Given this list of marker genes PITPNM3, CENPF, RPGRIP1, PEX6, FGFR3, MVK (mevalonate kinase), IDH3A, WT1, LYZ, BEST1, DLK1, METTL27, CYP27A1, MT-CO1, SEMA4A, ZNF513, DDB2, BBS5, UFD1, GLA, PRPH2, ATF6, EPAS1, HEXA, LRAT, WIPF1, USP45, PSMB8, ERCC6, RAX2, RTL1, CCDC28B, ABCC6, ERCC2, TGFBI, SPATA7, LYN, OFD1, CCM2, PRPF6, ARL2BP, TFRC, YME1L1, ERCC3, MASP1, ARVCF, TBL2, FKBP6, KIAA1549, MT-CYB, RAG2, NEK2, HK1, CNNM4 (NCBI Gene Id 619531), SPI1, RGR, NCF1, RTTN, NEK1, MPLKIP, MT-ND1, AIPL1, PIK3R1 (NCBI Gene Id 5295), CARS1, MERTK, MAK, PDE6A, GTF2IRD2, NOD2 (NCBI Gene Id 8135), HSD11B2, TNFRSF13B, MT-ND4, AHI1, DNMT3B, AP1G1, SDHD, IGSF3, NRL, LAMB2, CFAP418, GMPPA, TNFRSF13C, TOPORS, NUS1, IMPG2, CLCNKB (NCBI Gene Id 1188), RNF113A, FGF10, SLC6A6, SNRNP200, ASAH1, FZD4, CACNA2D4, CNGA1 (cyclic nucleotide gated channel subunit alpha 1), SHMT2, GNAT2, COL4A1, EFEMP1, LCA5, CDHR1, MAPT, IGFBP7, SDHC, FRG1, GJB6, MTTP, KLRC4, SAG, KLHL7, AARS1, MEFV, ESS2, RP2, STAT4, C4A (NCBI Gene Id 720), SAMD9, IGHM, RDH12, OPN1LW, PSMB4, PDCD10, JMJD1C, IARS2, ARL6, HIRA, STN1, NBN, FSCN2, HBB, LRBA, GPIHBP1, SMPD1, BTD, ESAM, AEBP1, SLC39A4, ANTXR1, AAAS, MT-ATP6, LIMK1, ZFX, CNGB3, DNMT3A, STX16, BUD23, FLVCR1, PDE6C, SETD2, TCF3, TBK1, POLH, GUCY2D, BTNL2, CR2, RPE65, BBS2, NDP, TP63, PLG, ARV1, EYS, TRIM44, HGSNAT, TBX1, RP9, HLA-DRB1, GUCA1B, SERPINC1, VPS37D, CTNNB1, ADA2, DKC1, TARS1, COMT, IMPDH1, RREB1, DNAJC30, BAZ1B, DHDDS, ABCA4, PRPF31, CCR1, PAX1, STX11 (syntaxin 11), NDUFS2, IMPG1, ADAM9, WDR19, IFNGR1, RBP3, CTSA, TMEM270, IL10, SASH1, CD19, ARL3, MT-ND5 (NCBI Gene Id 4540), IDH3B, FAM161A, DARS1, MEG3, NR2E3, ENG, RDH5, MYD88, SLC7A14, PCNA, ENPP1, DUX4L1, RET, ACVRL1, ATP2A2, XPA, IFT88, STX1A, FH, LCK, SMAD4, RHO, DRAM2, AIRE, MANBA, BTK (NCBI Gene Id 695), MT-ND2 (NCBI Gene Id 4536), SREBF1, SLC24A1, ERCC4, SCN9A (NCBI Gene Id 93955), APOE (NCBI Gene Id 99), VHL, GTF2E2, DGCR8, RFC2, PAX6, POMGNT1, PRCD, PCARE, IL23R, USH2A, TSPAN12, GLB1, LIG1, AHR, GTF2H5, XPC, RNF168, USB1, CCND1, IKZF1, SMCHD1, RP1, APOC2, CRB1, GDF2, MDH2, DUX4, RECQL, FOXC2, IVNS1ABP, GNAQ, MT-CO3, IFT172, ALMS1, RAG1, ERF, ELN, GGCX, ARHGEF18, IL12A, CNGA3, CD79B (NCBI Gene Id 974), NF1, CLRN1, HLA-B, FAS, TULP1, SELENOI, GNAS (NCBI Gene Id 82944), MLXIPL, TRNT1, CACNA1F, ERCC5, DNASE1L3, PROM1, CA4, CAPN5, RPGR, GUCA1A, NMNAT1, IFT140, VPS33A, TKT, WAS, TNFRSF1A, FGFR2, PRPF8, SDHA, FUCA1, TTC8, PDE6B, HEXB, RLBP1 (NCBI Gene Id 6017), CC2D2A, CD79A, IFT43, TLR4, PRPF4, SLC25A11, AGBL5, HLCS, CERKL, GM2A, ANO10, NAGA, IL12A-AS1, HARS1, LPL, COL17A1, RNF125, SDHAF2, POC1B, ERAP1, GP1BB, TUB, DGCR6, GATA1, DLST, GALC, KIF1B, UROD, ZNF408 (NCBI Gene Id 79797), NLRP3, GTF2I, PDE6H, ERCC1, PSAP, SSBP1, TTLL5, TMEM127 (transmembrane protein 127), LOXL1, RDH11, BBS1, SLC39A7, ERCC8, ROM1 (retinal outer segment membrane protein 1), IGLL1, SLC37A4, BLNK, ICOS, NLRP1, AP1B1, GSN, ATM, LBR, CLIP2, KRIT1, CFAP410, LRP5 (NCBI Gene Id 8058), HLA-A, FBN1, MT-ND4L, SEC24C, EIF4H, G6PC1, TLCD3B, RAB28, OPN1MW, MAB21L1, BBS9 (NCBI Gene Id 27241), CRX, LRRC8A, MKS1, LRRC32, GTF2IRD1, CNGB1, DHX38, PIK3CA, RP1L1, PDE6G, PTPN22, FOXC1, F12, KIZ, SETX, COL7A1, PRPF3 (NCBI Gene Id 9129), TREX1 (NCBI Gene Id 82474), GJB2, CHM, UBAC2, MYOC, TRAPPC11, SCAPER, SDHB, MAX, FGF12, REEP6, DGCR2, MT-ND6, CYP1B1, FERMT1, UNC119, COL18A1, RIMS1, UROS, KAT6A, ETHE1, IKBKG, MBTPS2, CLCC1, NEU1, CTC1 (NCBI Gene Id 80169), here is a description of the gene set: Human Gene Set: HP_ABNORMALITY_OF_THE_VASCULATURE_OF_THE_EYE studied in species Homo sapiens Abnormality of the vasculature of the eye